Given this list of marker genes Dusp10, Dusp7, Dusp16 (dual specificity phosphatase 16), Dusp21, Dusp1, Dusp6, Dusp4, Dusp8, Dusp2, Dusp14, Dusp5, Dusp18, Dusp9, here is a description of the gene set: Mouse Gene Set: GOMF_MAP_KINASE_TYROSINE_SERINE_THREONINE_PHOSPHATASE_ACTIVITY studied in species Mus musculus Catalysis of the reaction: MAP kinase serine/threonine/tyrosine phosphate + H2O = MAP kinase serine/threonine/tyrosine + phosphate.